Given this list of marker genes PIM1, MYD88, NMI, SLC6A12 (NCBI Gene Id 6539), SECTM1, MOB1A, TMEM109, HERC5 (NCBI Gene Id 51191), MX2, APOL1, RCN1, SCO2, IRF7, CFB, STAP1, ST3GAL5, FAS, PLA2G4A, SLIT2, RSU1, ERLIN1, IRF1, SYNC, MT1HL1, H1-6, TMSB10, FGL2, GLRX, PSMA4, SLAMF7, TLN2, PRPS2, NTN1, PML, LYN, MVP, GK3, DESI1, ARID5A, PLAAT4, HLA-DPB1, PANX1, ISOC1, OAS3, PSMB9, SELL (NCBI Gene Id 6402), TNFSF10, APOL6, SNX10, TAP2 (transporter 2, ATP binding cassette subfamily B member), RAPGEF2, TAP1, ARF3, WARS1, SLC37A1, PSMB2, PCDHA2, FCGR1BP, GCH1, CD40, MT1X, PSTPIP2, BTF3P11, LIMK2, LAG3, IFIT3, DDX60, ADAR, LPIN2, VRK2, RHBDF2, BTN3A3, KLF4, NHEJ1, RHOBTB3, CRYBG1, ISG20, IFI44, RBCK1, HLA-E, RSAD2, HLA-DQB1, PSMB10, RNF114, IFITM3, PNO1, APOBEC3G, GBP1, DYNLT1, CXCL11, CSTF3, SCARF1, DENND1A, IFITM1, SP110, JAK2, UBE2N, MYOF, VPS9D1, PPP3CC, IFIH1, TMX1, GIMAP6, ERAP2 (NCBI Gene Id 87126), ANK2, POLR3C, SEPTIN4, TAPBPL, STAT1, SFT2D2, P2RY14, PARP12, CXCL9, VAMP5, ATG3, CASP5, PSME1, LAP3, TNFAIP2, IDO1, EZH2, TOP1, APOL2, ASCL2, PAK1, TRIM22, SBNO2, C5orf15, LGALS3BP (NCBI Gene Id 3959), TGM2, GIMAP4, HCP5, GK, CD47, HLA-DRB1, NOD2, SP140, IL15RA, IL15, DR1, PSME4, N4BP1, SMCO4, CYLD, IFI27, CXCL10, SNAP91, ISG15, SOCS1, PSME2, ICAM1, PDE4B, UBE2Z, AMD1, CUL1, C1S, BAZ1A, UBP1, APOL3, TRAFD1, RALB, RMDN3, CST7, PSMB8, MCL1, RNF19B, STOM, IFI35, C1RL, PTGES3, IL32, SERPING1, DDX47, CIITA, MTHFD1, MT1H, CD38 (NCBI Gene Id 952), PHF11, UBE2A, BTN2A2, HLA-F, LMNB1, SOS1, PLEK, PSMA2, GBP2 (guanylate binding protein 2), MX1, MMP20, UBE2L6, ADGRE5, TDRD7, AIM2, IFIT5, CALCOCO2, DIPK1A, CES1, LY6E, SSPN, RTP4, AK2, here is a description of the gene set: Genes down-regulated in comparison of control microglia cells versus those 24 h after stimulation with IFNG. from publication Rock RB, Hu S, Deshpande A, Munir S, May BJ, Baker CA, Peterson PK, Kapur V (PMID 16163375) Microglial cells are resident macrophages in the central nervous system (CNS) and play a pivotal role in the innate and adaptive immune responses against microbial infections. The immune functions of microglia are regulated by a milieu of cytokines including interferon (IFN)-gamma. We here performed a series of experiments to acertain the transcriptional profile of human fetal microglial cells at 1, 6, and 24 h after IFN-gamma treatment. Primary human microglial cells were either untreated or treated with 200u/ml IFN-gamma. Affymetrix U133A chips were utilized. Four different tissue samples (B18, O, W, and Y20) were analyzed at the three time points. Human Gene Set: GSE1432_CTRL_VS_IFNG_24H_MICROGLIA_DN studied in species Homo sapiens